Given this list of marker genes TGFBR2, TGFBR1, TGFB1, here is a description of the gene set: part of: Loss of Function of TGFBR2 in Cancer Missense mutations in the kinase domain (KD) of TGF-beta receptor II (TGFBR2) are found in ~20% of microsatellite stable (MSS) colon cancers and make affected tumors resistant to TGF-beta (TGFB1)-mediated growth inhibition. While both alleles of TGFBR2 are affected by inactivating mutations in MSS colorectal cancer, a study of MSS esophageal carcinoma indicates that TGFBR2 KD mutations may function in a dominant-negative way. KD mutations in TGFBR2 are rarely reported in microsatellite instable (MSI) colorectal cancer. studied in species Homo sapiens Reactome Pathway: TGFBR2 Kinase Domain Mutants in Cancer